The following is a description of a gene set: studied in species Homo sapiens Human Gene Set: GOBP_ACTIVATION_OF_PROTEIN_KINASE_B_ACTIVITY Any process that initiates the activity of the inactive enzyme protein kinase B., and this is the list of marker genes: IGF1, ITGB1BP1, MT3, NRG1, DYNAP, PPIA, FGF1, GAS6